The following is a description of a gene set: Systems vaccinology has emerged as an interdisciplinary field that combines systems wide measurements and network and predictive modeling applied to vaccinology. Here we used the systems vaccinology approach to study the molecular mechanisms underlying the innate responses to the trivalent inactivated influenza (TIV) and live attenuated influenza (LAIV) vaccination in humans, and to identify early gene signatures that predict the magnitude of the antibody responses to influenza vaccination. Genes up-regulated in comparison of peripheral blood mononuclear cells (PBMC) from LAIV influenza vaccine pre-vaccination versus those at day 7 post-vaccination. species: Homo sapiens Human Gene Set: GSE29615_CTRL_VS_DAY7_LAIV_FLU_VACCINE_PBMC_UP from publication Nakaya HI, Wrammert J, Lee EK, Racioppi L, Marie-Kunze S, Haining WN, Means AR, Kasturi SP, Khan N, Li GM, McCausland M, Kanchan V, Kokko KE, Li S, Elbein R, Mehta AK, Aderem A, Subbarao K, Ahmed R, Pulendran B (PMID 21743478), and this is the list of marker genes: PLP1, ETNK2, TUBB1, CNIH3, TEX38, EPHA8, SNAP91, GGT2P (gamma-glutamyltransferase 2, pseudogene), SLC8A2, MBOAT7, MMP8, MMP25, MED9, SPATA2, BPI, MZB1, KDM4B, ANO1, BCL10-AS1, HGF, MMD, FZD5, ALLC, BAIAP2L2, MADCAM1, BRIX1, IL1RAP, ERC2-IT1, PLG, TLX1, SH2D4A, ADGRG4, C15orf48, MORN5, TTTY7, SLC25A51, MARCHF2, PCDHGA10, TRPV5, DDN, AMOT, HEY1, ADRA2A, TSPAN10, AMT (aminomethyltransferase), ANKRD22, KDM7A-DT, GPR15, KRT32 (keratin 32), IL1R2, ZNF527, TMEM186, OR2K2, APBA1, LINC01532, CYP4F2 (NCBI Gene Id 8529), OR6A2, CHI3L1, VNN3P, DLX6-AS1, KCNK16, PRR29, GPR83, RGR, PITX3, BASP1, COL22A1, MLF2, LINC02153, MUL1, PEX12, PRKAG2-AS2, NCF4, PWRN2, GPS2, TUNAR, LIMK2, NKX2-5, TNFRSF17, LMCD1, C1orf53 (chromosome 1 open reading frame 53), LRRK1, NAV3, NDRG4, COLEC12, MMP9, NEIL3, FENDRR, ECSCR, H2AC6, FOXR2, KRT23, RNASE3, MICALL2, LINC00668, RBMS3, KCNJ15, C1QL1, ENSG00000250685, ZNF598, FREY1, PF4, KCNS3, PCDHB1, GFER, ADGRG3, RSPH9, AVP, GNG10, SURF4, C4BPA, RHOF, FAM167B, RGS18, PIK3R6, GUCA1A, LYRM1, GNAO1-DT, TERT, SIPA1L2, LRRC34, LRTOMT, LINC00658, CORIN, SPANXA2-OT1, NT5DC2, PPP1R27, ZNF835, MMRN2, CDH7, ELANE, PLCH2, IL5RA, SYT6, GRM2, MGAM, UGT2B28, XAB2, COL17A1, SV2B, TBC1D10B, CA4, NTNG1, PPBP, CHDH, HOMER2, SPRR2G, CCN3, SERPING1, TOP2A, CXCL1, TNFRSF10C, DCST2, CTAGE11P, GALR3, SLC12A2-DT, REG3A, CYP4F3, ASIC5 (acid sensing ion channel subunit family member 5), ATP10B (ATPase phospholipid transporting 10B (putative)), TNFRSF13C, DEPDC1, LRRIQ1, ABTB1, NRAV, IGKV3-20, YWHAH-AS1, GZF1, FRMPD3, KATNAL1, TFCP2L1 (transcription factor CP2 like 1), TBC1D8, PAX9, CAVIN2, CYSTM1, ENSG00000280119, ZDHHC18, HAS1, ERI2, REG4, RBPMS2, RSU1P2, TYRP1, ACOT12, RPGRIP1L, CACNB1, TRAPPC13, CIRBP-AS1, ZNF446, KCNJ5, DZANK1, PPP2R5B, AR, DNAH17-AS1